The following is a description of a gene set: Mouse Gene Set: GOBP_REGULATION_OF_STEM_CELL_PROLIFERATION species: Mus musculus Any process that modulates the frequency, rate or extent of stem cell proliferation. A stem cell is a cell that retains the ability to divide and proliferate throughout life to provide progenitor cells that can differentiate into specialized cells., and this is the list of marker genes: Fermt1, Mir320, Ace, Kdm1a, Nf2, Epcam, Trp53, Cebpa, Ncoa3, Dgcr8, Tbx3, Pbx1, Dppa2, Hmga2, Trp63, Sfn, Fgf4, Nfib, N4bp2l2, Mir205 (NCBI Gene Id 387201), Wnt1, Kdf1, Vegfc, Osr2, Cd109, Nr2e1, Fermt2, Tlx1, Cdkn2c, Kdr, Ell3, Mpl, Sox17, Setd1a, Ptch1, Pim1, Prl2c3, Tert, Lrp6, Prrx1, Sox18, Ago3, Kitl, Fgfr1, Pax3, Septin4, Hmx2, Gli3, Ctnnb1, Runx2, Ltbp3, Wnt5a, Sox11, Tgfb1, Thpo, Hnrnpu, Zfp36l1, Tgfbr2, Hmgb2, Irf6, Irgm1, Ovol2, Gli2, Tgfbr1, Rarb, Kat7, Fgf8 (NCBI Gene Id 14179), Yap1 (yes-associated protein 1), Ngf, Bmp4, Mir702, Prrx2, Mecom, Rbpj, Hdac5, Nfatc1, Ovol1, Notch1, Wnt10b, Nf1, Sox9, Sirt6 (sirtuin 6), Shh, Shox2, Gja1, Fgf10, Hoxa3, Snai2, Pdcd2, Fgf2, Fbln1 (fibulin 1), Tsc22d1, Eif2ak2, Atxn1l, Tbx18, Taf4b, Fgf9, AY074887, Foxm1, Cxcl1, Rarg, Tial1, Ccne1, Men1, Wnt11, Fgfr2, Ptprc